The following is a description of a gene set: species: Homo sapiens Human Gene Set: MIR6506_3P Genes predicted to be targets of miRBase v22 microRNA hsa-miR-6506-3p in miRDB v6.0 with MirTarget v4 prediction scores > 80 (high confidence targets). from publication Chen Y, Wang X (PMID 31504780), and this is the list of marker genes: ZNF615, UBE2G1, ZSCAN31, ERLIN1, FYB1, DLL1